The following is a description of a gene set: species: Mus musculus Mouse Gene Set: chr6B3, and this is the list of marker genes: Vmn1r10, Gm24230, Gars1, Hibadh, Pyurf, Vmn1r-ps12, Vmn1r21, 9130019P16Rik, Ghrhr, Gm19237, Gm3793, Ggct, Vmn1r-ps16, Vmn1r26, Rps8-ps3, Gprin3, Ppp1r17, Hoxa1, Hoxa9, Vmn1r27, Gm18012, Herc6, Hoxaas2, n-R5s162, Mmrn1, Lsm5, Gm35077, Scrn1, Snca, Prr15, Hoxaas3, Gm38811, Gm22493, 9530018H14Rik, Mageb16-ps2, Crhr2, Gm5306, Pde1c, Gm44008, Vmn1r-ps17, Vmn1r-ps20 (vomeronasal 1 receptor, pseudogene 20), Vmn1r5, Vmn1r20, 5730596B20Rik, Vmn1r-ps23, Vmn1r-ps9, Vmn1r-ps8, Vmn1r11, Neurod6, Vmn1r29, Gm44026, Vmn1r23, Cbx3, Vmn1r14, Hoxa13, Gm24355 (NCBI Gene Id 115490472), Mir196b, Vmn1r-ps13, Vmn1r-ps22, Vmn1r25, Gm15573, Wipf3, Gm6695, Vmn1r28, Gm4872, Ppm1k, Hoxa11, Hottip, Hoxa5, Gm15050, Gm31579 (predicted gene, 31579), Vmn1r7, Hoxa10, Itprid1, Vmn1r-ps18, Gm34358, Nt5c3 (NCBI Gene Id 76506), Vmn1r4, Gm8129, Vmn1r-ps19, Vmn1r-ps11, Gm19244, Gm8143, Evx1os, Vmn1r-ps21 (NCBI Gene Id 100416926), Gm15572, Plekha8, Hotairm1, A730020E08Rik, Rps15-ps2, Vmn1r19, Cpvl, Vmn1r-ps10, Gm19165, A530053G22Rik, Hoxa3, Gm25726, Vmn1r15, Vmn1r30, Vmn1r17, Hnrnpa2b1, Vmn1r9, Vmn1r8, Ccser1, Snx10, Gm32479, Kbtbd2 (kelch repeat and BTB (POZ) domain containing 2), Mir3470a, Gm16499, Vmn1r6, Skap2, Halr1, Hoxa4, Herc3, Jazf1, Chn2, Hoxa11os, Creb5, Vmn1r12, Gm15527, Vmn1r-ps14, Fam13a, Aqp1, Vmn1r31, Hoxa7, Hoxa6, 6430584L05Rik, 0610033M10Rik, Hoxa2, Vmn1r24, Gm3279, Mindy4, 4930533I22Rik, Mturn, Abcg2, 9530036M11Rik, Gm18838, Fkbp9, 4921529L05Rik, Nod1, Inmt (indolethylamine N-methyltransferase), 1700094M24Rik (NCBI Gene Id 74304), Tax1bp1, Vmn1r-ps15, Vmn1r22, Fkbp14, Adcyap1r1, Gm10209, Vopp1, Vmn1r13, Lancl2 (LanC (bacterial lantibiotic synthetase component C)-like 2), Mir148a, Avl9, Nap1l5, Gm5570, Vmn1r16, Tigd2, Gm35386, Gm6559, Evx1, Tril, Vmn1r18, Gm15526, Nfe2l3, Znrf2